Given this list of marker genes P2RX1, SLC29A4, SLC29A3, LILRB1, HTR1B, FCER1G, SLC6A4, ITGB3, GPM6B, SLC22A1 (solute carrier family 22 member 1), SLC22A3 (NCBI Gene Id 6581), SLC18A1, SNCA, SLC18B1, HTR1A, NOS1 (nitric oxide synthase 1), SYK, SLC18A3, SLC18A2, SLC22A2, CRH, here is a description of the gene set: Human Gene Set: GOBP_SEROTONIN_TRANSPORT The directed movement of serotonin into, out of or within a cell, or between cells, by means of some agent such as a transporter or pore. Serotonin (5-hydroxytryptamine) is a monoamine neurotransmitter occurring in the peripheral and central nervous systems. species: Homo sapiens